Given this list of marker genes Tacr1, Slc6a18, Ednra, Sulf2 (NCBI Gene Id 99203), Npr3, Corin, Aqp4, Nfat5, Agtr1b, Itga3, Clcnkb, Ren1, Ppp3ca, Adora2a, Atp6v0a4, Rhpn1, Mas1 (MAS1 oncogene), Or51e2, Uts2 (NCBI Gene Id 24111), Adipoq, Atp6v1b1 (ATPase, H+ transporting, lysosomal V1 subunit B1), Slc4a5, Sucnr1, Lgmn, Myo1e, Pdgfb, Cyp2j5, Trpv1, Scn11a, Mrgprd (MAS-related GPR, member D), Dab2 (disabled 2, mitogen-responsive phosphoprotein), Adrb2, Psap, Ednrb, Kcnma1, Rhoa, Adgrf5, Adgrf4, Maged2, Cd34, Chrnb4, Kcnj1, Stc1, Btc, Tbc1d8b, Akr1b1, Slc5a1, Jchain, Spx, Aqp2, Hsd11b2, Adcy6, Slc4a1 (NCBI Gene Id 20533), Cldn4, Drd2, Ptger4, Agtr2, Aqp1, Gas6, Serpinf2, Ang2 (angiogenin, ribonuclease A family, member 2), Ptpro, Ctns, Aqp6, Nppb, Abcg2, Prkrip1, Cacna1c (calcium channel, voltage-dependent, L type, alpha 1C subunit), Comt, Kirrel1, Slc15a2, Guca2b, Kcnn4, Edn1, Adora1, Oxsr1, Ttr, Bcr, Cldn19, Gja1, Sctr, Umod, Kcnq1, Cln3 (CLN3 lysosomal/endosomal transmembrane protein, battenin), Akap11, Nherf1, Agtr1a, Scnn1b, Gsn, Bmp4, Inpp5k, Emp2, Coro2b, Ptger3, Mcam, Chrna3 (NCBI Gene Id 235388), Nr3c2, Bcl2, F2r, Clcn5, Uts2r, Oprl1, Avpr2, G6pdx (NCBI Gene Id 14381), Adrb1, Cyba, Pon3, Rrm2b, Tmem63c, Sulf1, Gnai2, Oit3, Oxt, Trpv5, Aqp7, Aqp3, Slc25a23, Hnf1a, Abcg3, Gja5, Amn, Cd2ap, Agt, Xpnpep3, Wnk4, F2rl1, Cldn16, Slc22a6, Has2 (NCBI Gene Id 210441), Slc12a3 (NCBI Gene Id 20497), Mllt6 (NCBI Gene Id 246198), Cyp11b2, Stk39, Wfs1, Pkn1, Klhl3, Adm, Hyal2, Chrnb2, Rhpn2, Slc5a2, here is a description of the gene set: Mouse Gene Set: GOBP_RENAL_SYSTEM_PROCESS An organ system process carried out by any of the organs or tissues of the renal system. The renal system maintains fluid balance, and contributes to electrolyte balance, acid/base balance, and disposal of nitrogenous waste products. In humans, the renal system comprises a pair of kidneys, a pair of ureters, urinary bladder, urethra, sphincter muscle and associated blood vessels; in other species, the renal system may comprise related structures (e.g., nephrocytes and malpighian tubules in Drosophila). species: Mus musculus